Given this list of marker genes Nmur2, Tenm4, Gpnmb, Atp5f1a, Dmac2, Dtwd1, Sms, Cpsf6, Tfg, Cltrn, Ift52, Slc17a6, Cpeb4, Dnaaf9, Ccnh, Tmem33, Cdc42se2, Cecr2 (CECR2, histone acetyl-lysine reader, NCBI Gene Id 76549), Nts, Elp2, Mbnl2, Col11a2, Brinp2, Itga6, Slc35b4, Sh3rf1, Prrc2b, Hprt1, Fam217a, Jazf1, Npy2r, Txndc9, Fhip2b, Relt, Gtsf2, Elovl5 (NCBI Gene Id 68801), Tmem168, Nefm, Grm8, Hoxa9, Cybrd1, Acvr2a, Ggh, Scaf11, P2ry12, Pcdh19, Sanbr, Insig1, Epb41l1, Ifi207, Kif3c, Slc9a6, Irx2 (Iroquois homeobox 2), Zfp326, Chmp5, Oprk1, Plekhb2, Med13, Barhl2, Ube2l6, Naaladl2, Rdh10, Tspan3, Rnd3, Mis12, Caprin2, Dnajc21, Prrg1, Kdm6a, Tmx4, Akap7, Rab11fip4, Slc25a10, Erlin1, Csnk1g3, Gnpda1, Emx2, Ms4a4d, Skap2, Nisch, Magee1, Hycc2, Vav3, Tmem64, Herc1, here is a description of the gene set: Genes predicted to be targets of miRBase v22 microRNA mmu_miR_6911_3p in miRDB v6.0 with MirTarget v4 prediction scores > 80 (high confidence targets). from publication Chen Y, Wang X (PMID 31504780) species: Mus musculus Mouse Gene Set: MIR_6911_3P